Given this list of marker genes CYB5R4, CYB5R1, POR, NQO1, CYB5RL, CYB5R3, CYB5R2, here is a description of the gene set: species: Homo sapiens Human Gene Set: GOMF_CYTOCHROME_B5_REDUCTASE_ACTIVITY_ACTING_ON_NAD_P_H Catalysis of the reaction: NAD(P)H + H+ + 2 ferricytochrome b(5) = NAD(P)+ + 2 ferrocytochrome b(5).